Given this list of marker genes PAPOLA, SNRPB2, SDC2, GRPEL2, GULP1, FBXO9, CREBZF, KRIT1, SEC24B, FNBP1L, FZD5, ASPN, ZNF493, BICC1, PTPRE, CASP3, STXBP4 (syntaxin binding protein 4), CPSF6, PAK5, NF1, TVP23B, FAM241B, OSBPL6, NR3C2, PTEN, HK1, TCF7L2, NID1, ZFP36L1, OTUD4, MATCAP2, PSD3, PPP4R3B, CTNNB1, CGGBP1, EPHA5, FZD8, ARID1A, TBX15, ATAD2, HSPA14, MTREX, MYO5B, FAM168A (family with sequence similarity 168 member A), ABHD17B, DCP1A, SHTN1, CRISPLD1, DPY19L1, SRSF2, MEI4, DOCK11, RFK, CEBPD, ZFP3, CCNB3, ANKRD46, RASSF6, AKAP9 (A-kinase anchoring protein 9), RNF125, RAPGEF4, PPM1E, PTPRG, SPICE1, RPS6KA6 (ribosomal protein S6 kinase A6), YTHDF3, YES1, GNPNAT1, SLC30A5, BEST3, CDH19, GATA6, ASPH, BBX, LRRC58, MYBL1, LTN1, TVP23C, CHL1, ARHGAP35, PYGO1, SUGT1, NPHP1, HMGB2, HSPD1, IMPACT, MTRF1L, MTF1, KCNA4, SUZ12, NECAP1, C1orf198 (NCBI Gene Id 84886), CCNYL1 (cyclin Y like 1), MAP4K3, TRDN, DSE, DNAJB6, SIRT1, PAPOLG, SPRED1 (NCBI Gene Id 161742), CREM (cAMP responsive element modulator), UBR3 (NCBI Gene Id 130507), SEMA6D, FGFBP1, SREK1, TMEM263, ACVR2B, RAD51, YAF2, SLC10A7 (solute carrier family 10 member 7), IKBIP, TRPS1, ELAVL4, MYH9, C11orf52, LRRC37B, CAPRIN1, here is a description of the gene set: species: Homo sapiens from publication Chen Y, Wang X (PMID 31504780) Human Gene Set: MIR6512_5P Genes predicted to be targets of miRBase v22 microRNA hsa-miR-6512-5p in miRDB v6.0 with MirTarget v4 prediction scores > 80 (high confidence targets).